Given this list of marker genes Hspb1, Cryab, Des, Tnni3 (NCBI Gene Id 21954), Tnnt2, Myl2, Myh7b, Mybpc3, Lmod2, here is a description of the gene set: Mouse Gene Set: GOCC_CARDIAC_MYOFIBRIL A cardiac myofibril is a myofibril specific to cardiac muscle cells. species: Mus musculus